The following is a description of a gene set: Human Gene Set: GAO_STOMACH_24W_C5_PUTATIVE_PIT_CELL_PROGENITOR species: Homo sapiens from publication Gao S, Yan L, Wang R, Li J, Yong J, Zhou X, Wei Y, Wu X, Wang X, Fan X, Yan J, Zhi X, Gao Y, Guo H, Jin X, Wang W, Mao Y, Wang F, Wen L, Fu W, Ge H, Qiao J, Tang F (PMID 29802404), and this is the list of marker genes: PPP1R14A (protein phosphatase 1 regulatory inhibitor subunit 14A), P2RX4 (NCBI Gene Id 5025), RASSF3, ALDH1B1, LRRFIP2, LIMS2, BCL2, CFAP221, WFDC1, RPRD1B (regulation of nuclear pre-mRNA domain containing 1B), GBP2, WIF1, LAMA5, SMG8, NRXN3, BARX1, HACD1, NFIX, MICALL1, NPB, PIPOX, SRF, CORO1C, TMEM51, KCNMB1, SLC2A4, SGCA, RSPO3, MVB12B, CAPS, BCL11A, YBEY, LDB3, TIMM17A, TAFA4, ADRA1D, DIXDC1, HSPB8, TMEM47 (NCBI Gene Id 83604), SLC24A3, SBSPON, VSNL1, DHX35, FBXO32, CNN1, CFL2, SETD1B, IL17B, RTL5, OLR1, LRP5, AK4, ACTC1, BMPER, TNFAIP8